Given this list of marker genes MMP14, RAB23, TWIST1, BMP4, FREM1, FGF4, TGFB1, MMP16, GLI3, DCANP1, INSIG1, FOXN3, NEUROG1, INSIG2, MSX2, TMEM107, MEGF8, TIFAB, here is a description of the gene set: The process in which any suture between cranial and/or facial bones is generated and organized. studied in species Homo sapiens Human Gene Set: GOBP_CRANIOFACIAL_SUTURE_MORPHOGENESIS